The following is a description of a gene set: Discrete subnuclear bodies in the interchromatin nucleoplasmic space, often located adjacent to nuclear specks. 10-20 paraspeckles are typically found in human cell nuclei. studied in species Homo sapiens Human Gene Set: GOCC_PARASPECKLES, and this is the list of marker genes: NONO, NUDT21, BCL6 (NCBI Gene Id 604), ALKBH5, SFPQ, NEAT1, BCL11A, HNRNPM, CPSF6, PSPC1